Given this list of marker genes Bcat2, Ilvbl, Dao, Mccc1, Auh, Agxt2 (alanine-glyoxylate aminotransferase 2), Hmgcl, Bcat1, Mccc2 (methylcrotonoyl-Coenzyme A carboxylase 2 (beta)), Gpt2, Bckdk, Ivd, Agxt, Hmgcll1, Gpt, here is a description of the gene set: The chemical reactions and pathways involving any amino acid that requires pyruvate for its synthesis, e.g. alanine. studied in species Mus musculus Mouse Gene Set: GOBP_PYRUVATE_FAMILY_AMINO_ACID_METABOLIC_PROCESS